Given this list of marker genes FSBP, DAB1, CNTLN, IGFBP5, FURIN, CRY2, SUFU, BIN1, CXCL13, CREM, ZFPM1, EMX2, CLRN3, SYN1, GPM6A, KCNK3, OLIG3, MAML3, CS, RHBDL3, LEMD1, CBL, CMAS, UBR5, CCSER2, APOO, HIC1, MYRF, TMEM196, NRP2, CDC42EP3, AP3S1, ZNF407, AQP2, JUN, CALHM5, NTF4, TTN, AMHR2, EGR2, CACNA2D3, ING4, KRT72, STC2, RLIM, BMP6, CLDN2, SUSD1, MINK1, TNXB, RAB3C, AMIGO2, SLC39A8 (NCBI Gene Id 64116), CLEC4E, LYL1, GLG1, NEUROD6, APOOL, IL1RL1, JPH1, KCNJ13, ABL1, LARP1, SUV39H1, ESRRG, CCL27, TSPAN12, NR5A2 (NCBI Gene Id 8768), RAB6C, ZBTB18, FGF13 (NCBI Gene Id 730528), ILRUN, EPB42, CCNE1, GPR155, LINC00670, SCHIP1, UBE2F, ELAVL4, DMD, TBX5, INHA, LHX6, SOX11, TBX4, UBE2H, B4GALT3, PHOX2B, NCDN, MASP1, HNMT, LCN15, SLC36A2, SEMA6A, BMP4, CACNA1F, SLC8A3, ERG (NCBI Gene Id 2078), MCU, CELF4 (NCBI Gene Id 56853), IKZF2, DENND1B, HHEX, VCPKMT, SLC24A5, TRIML1, DOCK8-AS1, RAB24, FAM162A, CREB5, ANKRD44, SH2B3, SH3KBP1, TLX1, TNRC6C, RBPMS, HNRNPA2B1, BCL6, KCNJ10, HAGHL, B4GALT2, UBE2B, AJUBA, SKIL, FLI1, PCDH7, KDM3A, POU4F2, FMO1, ECT2, HOXB8, IRX5, GRID2, LIX1, APBA1, SLC27A3, SIX1, SETD2, GUCA2A, PFKFB1, WNT2B, CHD2, MOS, SPMIP6, NOCT, PRELID1, EN1, SKIDA1, PELI2 (NCBI Gene Id 93480), PLEKHG6, PDHA2 (pyruvate dehydrogenase E1 subunit alpha 2), ISL1, STON2, CDON, OTC, ANGPT1, NFIB, FAM107B, ZMAT4, EIF4A1, PDC, CNTN6, ELF1, PILRB, CACNB2, NHLH2 (NCBI Gene Id 90888), REG4, HOXB6, LIFR, FBXO11, LINC02872, TAFA1, MAP4K4, MYT1, CTCF (NCBI Gene Id 10664), PDZD2, MCTS1, GRK6, DCAF11, STAG3L4, ATG12, MBNL1, NR5A1, RUNX1T1, PLA2G1B (NCBI Gene Id 5319), CTNNA3, FOSL2, SPRY4, ZNF219, CREBL2, TM4SF5, PSD4, IL34, WNT16, PNLIPRP1, FAM106A, MGAT4C, RALGPS2, TSC22D3, MITF, IKZF4, CDC42EP2, SLC26A9, EML4, XPR1, RFX4 (regulatory factor X4), PRDX2, GPX1, CACNA1C, ZNF326, BCL2L1, SMOX, SNCA, PDGFRA, ACKR1, HDAC9, VSTM2A, PDPN (NCBI Gene Id 29912), NECTIN2, ADCY6, SGIP1, SATB2, PMS2P5, MYH6, CAPN1, HS3ST5, PITX2, CUL2, SLC4A1, ACTR1A, SATB1, HNRNPL, ALDOB, ADGRF5, SCUBE3, ELAVL2 (NCBI Gene Id 1993, ELAV like RNA binding protein 2), HBZ, CAST, RORA, XPO6, MORC4, TNK2, UBE2U, PLEKHB1, ZNF385B, BNC2, IL13, TFR2, JARID2, here is a description of the gene set: species: Homo sapiens Genes having at least one occurrence of the motif NNNNNGATANKGNN in the regions spanning 4 kb centered on their transcription starting sites. This matches the GATA1 transcription factor binding site V$GATA1_02 (v7.4 TRANSFAC). Human Gene Set: GATA1_02